Given this list of marker genes Ott, Ap1s2, Pfdn4 (prefoldin 4), Steap2, Sim1, Plekhd1, Rab2a, Trio, Evi5, Gria1, Fam114a1, Gm15091, Raph1, Asap3, Lcorl, Klra5, Myo1c, Gnaq, Lin9, Srpk2, Bcl11a, Dyrk1a, Pom121l2, Ube2d3, Wnk3, Ankrd1, Itsn1, Tbc1d30, Azi2, Sorbs2, F8a, Baz2a, Kansl1, Rbms1, Gpbp1l1, Lhfpl6, Inpp4b, 4930524B15Rik, Rsbn1l, Pum2, Dpm1, Gm10439, Ranbp9, Phip, Ipo5, Speer4b, Mfsd14a, Cyp39a1, Pbx1, Otx2 (NCBI Gene Id 218991), Sirt1, Rictor, Slc5a7, Pdcd6ip, Wdcp, Kcnc2, Sbno1, Kcnb2, Klra7, F13b, Xkr4, Dyrk4, Gabpa, Gm15085, Sacm1l, Gpr141b, Abi1, N4bp2l2, Klhl24, Mgat2, Ash1l, Sema6a, Rnf13, Scoc, Zfp931, Trnt1 (tRNA nucleotidyl transferase, CCA-adding, 1), Pnp, Trhde, Nhsl3, Trp53inp1, Tfdp2, Gm15114, Rcbtb2, Itprid2, Oxr1, Gm15093, Prickle2, Slc2a3, Gm15080, Rsf1, BC005624, Gnptg, Car13, Ptprm, Slc7a14, Nppc, Nedd4, Kpna4, Stim2, Xxylt1, Gm15127, Cnot6, Cacybp, Rag1 (NCBI Gene Id 19373), Gm15097, Prpf4b (NCBI Gene Id 207915), Tafa2, Cramp1 (cramped chromatin regulator 1), Trpc1, here is a description of the gene set: from publication Chen Y, Wang X (PMID 31504780) Mouse Gene Set: MIR_491_3P Genes predicted to be targets of miRBase v22 microRNA mmu_miR_491_3p in miRDB v6.0 with MirTarget v4 prediction scores > 80 (high confidence targets). studied in species Mus musculus